The following is a description of a gene set: Any process that activates or increases the frequency, rate, or extent of a T-helper 1 type immune response. species: Homo sapiens Human Gene Set: GOBP_POSITIVE_REGULATION_OF_T_HELPER_1_TYPE_IMMUNE_RESPONSE, and this is the list of marker genes: IL23A, SLC11A1, IL12RB1, IL18R1, TBX21, IL23R (interleukin 23 receptor), NLRP10, IL1R1, SLAMF1, IL1B, IL27RA, XCL1, IL12B, ARID5A, PLA2G4A, IL18, RIPK2, CCR2